The following is a description of a gene set: Human Gene Set: GOMF_OLIGOPEPTIDE_TRANSMEMBRANE_TRANSPORTER_ACTIVITY Enables the transfer of oligopeptides from one side of a membrane to the other. Oligopeptides are molecules that contain a small number (2 to 20) of amino-acid residues connected by peptide linkages. species: Homo sapiens, and this is the list of marker genes: SLC25A40, MFSD1, ABCC5, ABCC1, SLC15A4, ABCC4, SLC15A1, SLC25A39, ABCB9, SLC15A2, SLC15A3, GJA1, SLC13A3